Given this list of marker genes RAB5A, ENPP2, MAP3K3, USP7, OSR1, JUND, STAT3, PLPP1, ZFP36L1, LRRN1 (leucine rich repeat neuronal 1), SMARCAD1, TRIM24, KLF5, WDFY3, CNTNAP3, SMIM3, B3GALT4, LINGO1 (leucine rich repeat and Ig domain containing 1), KAT6A, RPS3A, SUPT7L, SGMS1, MMP2, MED12, TALDO1, GTPBP3, ARMCX5, SNX5, SSBP2, LHPP, NEBL, PARG, RBM22, TRA2A, KCNN2 (potassium calcium-activated channel subfamily N member 2), COMMD3, SET, SKIL, TGIF2, COMMD7, DUSP12, MAGED2 (NCBI Gene Id 10916), CDYL, TCF20, KATNBL1 (katanin regulatory subunit B1 like 1), GADD45G, PIP5K1C, ZEB2, TAF12, JARID2, IER5L, TSC22D1, USP44, DPYSL3, RESF1, CDK17, AUH, JUP (NCBI Gene Id 3728), FGFR2 (NCBI Gene Id 2263), SPAG9, ZIC2, ANO8, NAXD, ATP6V1D, SORBS1, ABTB2, TFPT, GPC3, CAVIN3, CPT1A, RDH10, BAMBI, NCBP1, KLF7, DPYSL2, GRID2, MEIS2, TBL1XR1, CCN2, REST, GNPTAB, KIF15, SKA2, TIMM23B, KDM3A, ARID1B, THBS2, TRIP4, DUSP6, RIC8B, NANOG, FBXW11, MED11, WDR20, RNF24, ACD, DNAJC9, NUDT5, LARGE1, PSMA3, OGA, WEE1, PPP2R1B, MSC, PLAA, TJP3, CACNA2D1, DBR1, IRX2, GAP43, PIPOX, SPRED1, NEFL (NCBI Gene Id 4747), TAL1, IL1RAPL1, PHGDH, URM1, CABLES1, ZIC1, NR2F2 (nuclear receptor subfamily 2 group F member 2), DPPA4, KDR, ZKSCAN5, JPT1, SLC4A1AP, UBE2D3, GNG10, SFXN1, BUB3, PRPF31, IFI16, CHST5, FUS, HESX1, MLLT10 (MLLT10 histone lysine methyltransferase DOT1L cofactor), PRR11, PHF8, FGFR1, BLCAP, FICD, KCNMB4, TXN2, FRAT2, MKRN1 (makorin ring finger protein 1), JADE1, RAD54B, DPH6, ANKRD13C-DT, MRPL13, RAD51C, GAS1, EXOSC9, EPHA1, ELAVL2, UFM1, ICMT, SOX2, TCF7L1, CA2, SFRP2, PPP2R3A, STMN2, BUB1B, ICMT-DT, CDC14B, IST1, SULF1, ANKRD1, RFNG, PDCL, OBSL1, TRIM22, DHDDS, HMG20A, CDH1, ZDHHC6, COL12A1, YJU2, GRHL2, PRKRIP1, ATAD2, CDK14, TOP2A, WDR70, FEZ1 (fasciculation and elongation protein zeta 1), TRPS1, DKK1, EIF2S1, PRPF38A, TMEM170A, FGF2, CA4, NUCKS1, LEFTY2, KIAA1143, H2BC21, EOMES, ALKBH1, WDR36, ZMPSTE24, DTNA, GJA1, TMEM30A, DHRS3, CRIPTO, ADD3, AMIGO2, UBR5, H2AJ, SNRPN, SFRP1, TLE3, SLC44A1, KLHL4, ID2, PRPS1, NPLOC4, TSTD2, ORC1, HOXB5, MYEF2, POU5F1, JOSD1, KIFBP, PCLAF, LAMA4 (NCBI Gene Id 3910), CDC7, TNC, POLR3G (RNA polymerase III subunit G), ZHX2, BMP7, COA8, TNRC6A, GLDC, ATP6V1G1 (ATPase H+ transporting V1 subunit G1), GTPBP1, NFE2L3, ZIC3, HAS2, BAG5, OLFML3, SMG5, MTM1, FOXO1, EFL1, TBC1D22B, PTPN2, HHEX, GTF3C4, CAPZA2, NAA30, NEFM, KLHL5, AASDH, FZD10, RPL32, RPS18, PAK1, PARD3, CDC123, LRAT, VPS52, ANKHD1, PNISR, HMGB2, PBDC1, SRSF4, SLIRP, ROR1, KANK1, GPS1, PRDM14, SALL1, INF2, OBI1, DDX31, LSG1, GATA6, NAALAD2, MAN2C1, RASGRF2, TCF4, ENTPD1, LRFN3, SOX17, MCC, TCF12, ARPC5, CBY1, RIF1 (replication timing regulatory factor 1), here is a description of the gene set: Human Gene Set: BENPORATH_OCT4_TARGETS Cancer cells possess traits reminiscent of those ascribed to normal stem cells. It is unclear, however, whether these phenotypic similarities reflect the activity of common molecular pathways. Here, we analyze the enrichment patterns of gene sets associated with embryonic stem (ES) cell identity in the expression profiles of various human tumor types. We find that histologically poorly differentiated tumors show preferential overexpression of genes normally enriched in ES cells, combined with preferential repression of Polycomb-regulated genes. Moreover, activation targets of Nanog, Oct4, Sox2 and c-Myc are more frequently overexpressed in poorly differentiated tumors than in well-differentiated tumors. In breast cancers, this ES-like signature is associated with high-grade estrogen receptor (ER)-negative tumors, often of the basal-like subtype, and with poor clinical outcome. The ES signature is also present in poorly differentiated glioblastomas and bladder carcinomas. We identify a subset of ES cell-associated transcription regulators that are highly expressed in poorly differentiated tumors. Our results reveal a previously unknown link between genes associated with ES cell identity and the histopathological traits of tumors and support the possibility that these genes contribute to stem cell-like phenotypes shown by many tumors. studied in species Homo sapiens from publication Ben-Porath I, Thomson MW, Carey VJ, Ge R, Bell GW, Regev A, Weinberg RA (PMID 18443585) Set 'Oct4 targets': genes upregulated and identified by ChIP on chip as OCT4 transcription factor targets in human embryonic stem cells.